Given this list of marker genes CASP8AP2, PIK3R1, FAIM2, FGA, BAG3, RFFL, ZDHHC3, TNFRSF1A, NOS3, BLOC1S2, MADD, FAS, DAPK1, STX4, PEA15, PARK7, TNFRSF10C, GPX1, TMBIM1, CASP8, HGF, BAD, BMPR1B, ARHGEF2, FADD, BAX, CFLAR, FGB (fibrinogen beta chain), BRCA1, DDX47, MAL, NF1, TNFRSF10B, PMAIP1, STK3, SFRP1, TNFRSF10A, CRADD, GRINA, TNFAIP3, ICAM1, ITPRIP, SERPINE1, THBS1, BID, TNF, MOAP1, MIR221, SCRT2, SPI1, FASLG, FGG, LGALS3, DAXX, FAIM, TMC8, SP100, HMOX1, SFRP2, FAF1, DAB2IP (DAB2 interacting protein), PIDD1, GABARAP, TRADD, FEM1B, SORT1, BCL2, BCL2L1, TNFSF10, BMP5, GSK3B, DDX3X, MIR222, HMGB2, ZSWIM2, RNF34, STK4, ATF3, DIABLO, BEX3, RAF1, DEDD2, DEDD, SKIL, NGF, DELE1, here is a description of the gene set: Human Gene Set: GOBP_EXTRINSIC_APOPTOTIC_SIGNALING_PATHWAY_VIA_DEATH_DOMAIN_RECEPTORS The series of molecular signals in which a signal is conveyed from the cell surface to trigger the apoptotic death of a cell. The pathway starts with a ligand binding to a death domain receptor on the cell surface, and ends when the execution phase of apoptosis is triggered. studied in species Homo sapiens